The following is a description of a gene set: Protein complex that links the outer microtubule doublet of a 9+2 type ciliary or flagellar axoneme with the sheath that surrounds the central pair of microtubules. Composed of a stalk that attaches to each doublet microtubule and a globular structure (spoke head) that projects toward the central pair of microtubules. studied in species Mus musculus Mouse Gene Set: GOCC_RADIAL_SPOKE, and this is the list of marker genes: Rsph4a, Cfap61, Nme5, Rsph9, Ropn1l, Rsph3b, Rsph14 (NCBI Gene Id 71236), Rsph1, Cfap206, Iqub (NCBI Gene Id 214704), Rsph6a, Cfap119, Dydc1, Dnajb13, Cfap91, Rsph3a